Given this list of marker genes Usp14, Ubl3, Ints9, Daam2, Exosc9, Rnpc3, Fubp1, Med13l, Ago1, Me2, Stmn2, Nfia, Adal (adenosine deaminase-like), Gfap, Fryl, Tmtc2, Dyrk1a, Mmgt1, Srgap3, Map3k14, Arhgef6, Ddx17, Eif4a2, Trim52, Plekhb2, Cisd2, Polr3e, Yy1, Laptm5, Ubxn7, Gid4, Sbno1, Tenm3, Rapgef2, Lipt2, Pip4k2a, Timm44, Srpk2, Nfatc3, Pou2af2, Pgap1, Gpr85, Zmym3, Kras, Zfp655, Mnat1, Prpf4b, Car1, Saysd1, Fancl, Onecut2, Phf20l1, Ccdc3, Slc30a4, Cds2, Stard4, Brinp3, Ezh1, Lrrc40, Erv3, Dpysl2, Ccnj, Ptprr, Tshz3, Cav2, Moxd1, Idnk (NCBI Gene Id 75731), Zfp513, Naaladl2, Slc35g2, Maneal, Scn4b, Tmem52b, Nucks1, Epha7, Gpcpd1, Amph, Cdk13, Sp4, Sfmbt1, Sqle, Nfat5, Dennd4a, Megf9, Itgb1, Smarcad1, Tgfbr1 (transforming growth factor, beta receptor I), Adck2, Serpinb8, Foxf2, Med13, here is a description of the gene set: Genes predicted to be targets of miRBase v22 microRNA mmu_miR_6345 in miRDB v6.0 with MirTarget v4 prediction scores > 80 (high confidence targets). species: Mus musculus from publication Chen Y, Wang X (PMID 31504780) Mouse Gene Set: MIR_6345